The following is a description of a gene set: studied in species Mus musculus Any process that modulates the frequency, rate or extent of cardiocyte differentiation. Mouse Gene Set: GOBP_REGULATION_OF_CARDIOCYTE_DIFFERENTIATION, and this is the list of marker genes: Kat2a, Wnt3a, Mef2c, Hey2, Tgfb1, Efnb2, Tgfb2, Tbx5, Fzd7, Dll1, Ccnd2, Nkx2-5, Frs2, Dhx36, Prickle1, Sox17, Smad4, Nrg1, Hdac3, Gper1, Myocd, Gsk3b, Bmp4, Sox6, Dkk1, Arrb2, Egfr, Bmp2